The following is a description of a gene set: Enables the transmembrane transfer of a potassium ion by a delayed rectifying voltage-gated channel. A delayed rectifying current-voltage relation is one where channel activation kinetics are time-dependent, and inactivation is slow. Mouse Gene Set: GOMF_DELAYED_RECTIFIER_POTASSIUM_CHANNEL_ACTIVITY species: Mus musculus, and this is the list of marker genes: Kcne3, Kcna10, Kcna7, Kcna6, Kcnc3, Kcnh8, Kcnb1, Kcnc1, Kcna2, Kcne1, Kcna3, Kcnq1, Kcna5, Kcnc2, Kcnh2, Kcna1, Kcnb2, Kcnh1, Kcne5, Kcne4, Kcnc4, Kcns1, Kcnh5, Kcng1, Kcne2, Kcng4, Kcng3, Kcna4